Given this list of marker genes Cnot10, Il10rb, Ccnh, Donson, Exoc3, Mcm5, Mdm4, Usp4, Dusp3, here is a description of the gene set: Cytokines mediate cell-cell communication in the immune system and represent important therapeutic targets. A myriad of studies have highlighted their central role in immune function, yet we lack a global view of the cellular responses of each immune cell type to each cytokine. To address this gap, the authors created the Immune Dictionary, a compendium of single-cell transcriptomic profiles of more than 17 immune cell types in response to each of 86 cytokines (>1,400 cytokine-cell type combinations) in mouse lymph nodes in vivo. A cytokine-centric view of the dictionary revealed that most cytokines induce highly cell-type-specific responses. For example, the inflammatory cytokine interleukin-1β induces distinct gene programmes in almost every cell type. A cell-type-centric view of the dictionary identified more than 66 cytokine-driven cellular polarization states across immune cell types, including previously uncharacterized states such as an interleukin-18-induced polyfunctional natural killer cell state. species: Mus musculus Genes positively differentially expressed in cell type: B cell upon treatment with cytokine: FLT3L in mouse lymph nodes in vivo. from publication Cui A, Huang T, Li S, Ma A, Pérez JL, Sander C, Keskin DB, Wu CJ, Fraenkel E, Hacohen N (PMID 38057668) Mouse Gene Set: CUI_B_CELL_FLT3L_RESPONSE_UP